Given this list of marker genes PLK3, DUSP1, STX1A, RAP2C, THADA, PCDHGB2, CELF6, PABPC1, PREX1, SEMA5B, USP32P2, B4GALT2, TIMM8A, HOXA6, ANGPTL4, PCDHGB4, GAPVD1, CDC42, ARHGEF2, CTTNBP2, PPP4R3B, PCDHGC5, GANAB, AGK, CLTC, RAPGEF6, EIF5A, VAPB, MYCBP2, SCN2B, TRIM2, ARHGDIA, FOXG1, DLST, PTPN12, ACSL4, PCDHGB5, PAPPA, ACACA, ELF2, GABARAPL1, CREBZF, CD47, TGFBR1, CALML4, TNK2, PPP4R3A, ZMYM3, PCDHGA8, GRM5, NCKIPSD, ASIC2, ABCA3, NUMA1, NAB1, USP6 (ubiquitin specific peptidase 6), SENP1, CRYGS, CELF4 (NCBI Gene Id 56853), DIP2B, STK3, PCDHGA3, PCDHGA11, PCDHGB7, MARF1, SLC8A3, PIP5K1B, PCDHGA4, HMBOX1, CNTNAP1, MTCL2, SOCS5, CERS2, RANBP2, LPGAT1, PCDHGA1, MINK1, ACVR1B, PSMF1, ZFP91, PCDHGA12, CCDC117, CDR2L, PCDHGA6, FBXL20, AKAP10, PTBP2, CTBP2, OTUB2, MSN, USP32, NAA40, BCL2L1, APPL2, PCDHGA10, TNNI1, NFASC, COX6A1, NIPA1, TTYH3, RAG1, DOK1, SNX33, AVL9, SREK1, HIC2, ADGRB1, TPI1, PCDHGB3, CORO1B, AKAP9, POU4F1, PCDHGA2, PPP2R5D, NPTX1, ZC3H10 (zinc finger CCCH-type containing 10), PRRX1, STX5, PCDHGC3, RTN4RL1 (reticulon 4 receptor like 1), FAM118A, BAZ2A, TRAM1, PALD1, SOX11 (NCBI Gene Id 6664), DNAJB6, MIDEAS, OSBPL8, PRRT2, RETREG1, BACH1, IP6K1, PCDHGB1, CSF2, CACUL1, RAB11FIP1, FUS, CBL, BCL2L2, PPP1R12C, NELFA, PITX3, RAB14, PCDHGA9, PACSIN1, IL6ST, YTHDF3, FBXL2, MLLT3, KMT5A (NCBI Gene Id 387893), RING1, DDX3Y, PFKFB3, DDX3X (NCBI Gene Id 730543), PCDHGB6, PCDHGC4, TAGLN2, SECISBP2L, NNAT, SFSWAP, FKBP2, SLC7A8, NFAT5, YES1, TTBK1, FLOT2, PCDHGA7, CHKB, GRAMD1A, NCOA5, ARFIP2, WIPI2, ATOH8, DLG5, PCDHGA5, ZNF385A, GAS2L1, PAPSS1, AZIN1, TGIF2, AGBL5, RCE1, CXCL5, PPP1R9B, KCNH2, FAM117B, SLC19A2, CDK5R2, CDIP1, DNM2, RBBP4, MYH9, ZDHHC8, MECOM (MDS1 and EVI1 complex locus), SASH1, BAHD1, NHSL3, CARF, KIAA0040, SLC25A25, ST13, SRSF2, here is a description of the gene set: species: Homo sapiens Human Gene Set: GGGACCA_MIR133A_MIR133B Genes having at least one occurence of the motif GGGACCA in their 3' untranslated region. The motif represents putative target (that is, seed match) of human mature miRNAs hsa-miR-133a and hsa-miR-133b (v7.1 miRBase).